The following is a description of a gene set: species: Mus musculus Genes down-regulated in prefrontal cortex (PFC) of mice carrying a hemizygotic microdeletion in the 22q11.2 region. Individuals with 22q11.2 microdeletions show behavioral and cognitive deficits and are at high risk of developing schizophrenia. We analyzed an engineered mouse strain carrying a chromosomal deficiency spanning a segment syntenic to the human 22q11.2 locus. We uncovered a previously unknown alteration in the biogenesis of microRNAs (miRNAs) and identified a subset of brain miRNAs affected by the microdeletion. We provide evidence that the abnormal miRNA biogenesis emerges because of haploinsufficiency of the Dgcr8 gene, which encodes an RNA-binding moiety of the 'microprocessor' complex and contributes to the behavioral and neuronal deficits associated with the 22q11.2 microdeletion. Human Gene Set: STARK_PREFRONTAL_CORTEX_22Q11_DELETION_DN from publication Stark KL, Xu B, Bagchi A, Lai WS, Liu H, Hsu R, Wan X, Pavlidis P, Mills AA, Karayiorgou M, Gogos JA (PMID 18469815), and this is the list of marker genes: NME1, LAMTOR1, CYC1, NIPA1, EIF3L, PSMC3, GPR83, COA3, TMEM147, EIF2B4, BOK, NACA, COMMD8, DCAF11, B4GALT3, DGCR8, GLS2, RPL36A, PSMB4, NARS1, KPNA1, SCNM1, KXD1, NME2, NDUFB10, STIP1, OCIAD2, INCENP, RHEB, PPP1R9A, HAGHL, TCEAL8, PHIP, EIF4E, PURA, DPM2, SGTB, MRPS28, CCT5, TIMM17A, PSMB6, DTNBP1, SMIM7, NDUFA2, UFC1, MED28, MRPS18A, TMA7 (translation machinery associated 7 homolog), PRDX3, NDUFA12, C1GALT1C1, MAPK10, GPATCH8, TSHZ3 (teashirt zinc finger homeobox 3), SRA1, C22orf39, NAA38, SLC25A20, NSG2, TSPAN31, C9orf85, SEC22B, TXNRD2, PDGFA, LYSMD4, ATP5F1C, RAD23A, HSD17B7, HS3ST4, ATP6V1E1, PRDX1, TST, INIP, MVD, GPI, ARPC5L, ZNHIT1 (zinc finger HIT-type containing 1), MRPL55, MLLT6, RARS1, MDH2 (malate dehydrogenase 2), CREB3, RPL8, EIF3K, MKKS, SUMO1, C19orf25, HIBADH, RGS20, EIF2S1, CUEDC2 (NCBI Gene Id 79004), RIT1, RPL15, NUDC, DDX56, ADCY8, C1QTNF4, MRPL17, ATP6AP1, SCG5, COX14, NUDT21, HAGH, USP34, SAC3D1, IDH3A, MICOS10, IDH1, TESK1, WDR17, BCKDHB, LGI2, NIPSNAP1, NDUFAF3, CISD1, SCN2B, SDHAF4, COPS6, SNX32, PPT1, ATOX1, SARS1, HSPBP1, ERI3, ATP5PF, SEC61B, HMOX2, MRPS17, NDUFA7, FIG4 (NCBI Gene Id 9896), TXN, DGCR6, PLCB4, COMT, NDUFS7, TRBC2, MRPL51, MRPL40, SNRPD2, H2AC25 (H2A clustered histone 25), TRA2B, RMND5B, TUBG1, CBX3, NSD2, CYCS, THOC7, KPNA2, HIBCH, EPM2AIP1, HSPA4L, EIF3F, OGFOD3, NR1H2 (NCBI Gene Id 7376), NDUFS3 (NCBI Gene Id 4722), GCSH, VDAC3, HIRA, PDCD6, IMPACT (NCBI Gene Id 55364), FNTA, LEPROTL1, MGST3, MPC2, PRELID1, PFDN6, POP7, MIS18A, ATP5IF1, RPL5, TLE4, CNDP2, AP2M1, CWF19L1, GDE1, KANTR, MPPED2, ARHGAP20, CNPY2, MICOS13, CYSTM1, ARK2C, PSMA3, SAMD5, SMARCB1, PRPS2, MTLN (NCBI Gene Id 205251), MBLAC2, HSPE1, PSMC1, MRPS23, COPS3, PCDH11X, DENND5B, SMYD2, TRMT10B, RAD23B, HPF1, ATP5PO, UQCRC2, TMEM165, PLEKHO1, PSMB3, FKBP3, STRBP (NCBI Gene Id 55342), ADH5, IFTAP, NDUFB11, UQCR11, TMSB10, SIRT2, DYNLRB1, TTLL7, GTF3A, NOP10, ARHGAP35, TANGO2, AHSA1, OAT, EIF1, TMEM208, DMAC1, RAB4B, TMEM44, SNHG10 (NCBI Gene Id 317786), UQCR10, CLNS1A, NUP88, USP1, PGRMC2, MRPL15, TPI1, OSBPL1A, SEC62, POLR1D, CARM1, ST13, FDPS, ESS2, NPRL2, DYNLL1, SAP18, ATP5MF, NDUFS1, RTN4R, ALCAM, CHN2, UQCC5 (NCBI Gene Id 440957), STMN3, TAF9, CRYZL1, IDH3G, LAMTOR2, MRPL11, FNDC4, DCTN6, HAPLN4, DAP3, TIMM23 (NCBI Gene Id 100287932), PHC2, U2AF1L4, MRPS12, ATP5PD, CARF, AKR1A1, ZDHHC16, UQCRFS1, MZT2B (mitotic spindle organizing protein 2B), TRIR (NCBI Gene Id 79002), ATP6V1D, ATP5ME, WDR45, ELOB, STMN2, UFSP2, PRODH, RPL18, PPP2R5C, SBDS, TMEM59L, ZNF511, UQCC2, PFDN2, MCTS1, IFNGR2, TXNL4B, SRP9, NDUFA9, SRR, ALDOA, CACYBP, SAR1B, CLDN5, RUNDC3A, C1QBP, RNF34, ROMO1, NDUFB4, METTL26, CYB561A3, CPSF3, NDUFA8, GUK1, NDUFS4, TXNDC17, WDR82, FAM162A, ARHGAP15, SLC25A46, ENOPH1, PRDX2, TCP1, FN3K, MRPL41, MRPL28, SNAPC2, UGP2 (UDP-glucose pyrophosphorylase 2), FMC1, GET3, DDRGK1, SELENOH, PIP4P1, SMU1, VPS13A, GNG13, SNRNP27, RTRAF, PRAF2, ATP5MG, SLC27A4, GP1BB, PSMA2, CCT2, SEMA3A, MRPS11, IPO9, BRWD1, NAXE, MLLT11, DNAJC15, BCAP31, RABL6, PSMG2, UBAC1, KDM1A, ELOF1 (elongation factor 1), BLVRA, SNX16, TMEM42, SEC63, USP39, METTL8, FAM136A, EIF3H, NDUFS8, TRAPPC2L, KRTCAP2, ELP5, PPP1CA, SCAND1, MEA1, BBLN, MYL4, LRPAP1, TOMM34, PDCD5, ABHD11, MRPL3, DGCR2, EIF6, PPM1L, TMEFF2, NDUFB2, RRP7A, NONO, DIPK1B, SS18L2 (NCBI Gene Id 51188), ACTR10, ACSL1, POLR1C, NDUFV2, TOMM20, VDAC2 (NCBI Gene Id 7417), BUD31, CORO7, TRIM59, TCEAL9, PDXDC1, OMG, CDK5, CHCHD1, H2AZ1, TMEM126A, EMP2, PSMD14, GINS4, FKBP2, IST1 (IST1 factor associated with ESCRT-III), SERF2, TM7SF2, PDHB, TMX2, NMT2, UFD1, ACOT13, GSKIP, GLG1, PFDN5, NDUFA11, NAGK, ZFTRAF1, LRRC4C, SLITRK4, POMP, ZDHHC8, MPI, CHMP4B, PSMA5, BCAP29, AKR1B1, SNORA74A, NFU1, TPD52 (NCBI Gene Id 7163), BNIP1, UBL4A, SLC25A5, TBC1D9B, MRPS22, GDAP1, COQ4, BSCL2, EIF4G2, BCCIP, JKAMP, PAK1, B4GAT1, TMEM256, MRPL57, HIGD2A (NCBI Gene Id 90241), NFIX, POLR2J, SLC25A39, SPSB3, CBR1, RPS17, COX7C, TIMM8B, EEIG1, ANK3, PSMC4, ABT1, OGFRL1, C4orf3, COPRS, PDE6D, FH, ALAD, S100A6, RAB26, ATP5F1E, RPL34, SNX7, SLC25A1, SMIM29, DENR, PPIL3, TRMT2A, FABP3 (fatty acid binding protein 3), NDUFS6, VPS35, RAB5IF, RPL4, TRMT112, PKIB, SNRPC, WTAP, NIFK, ARAP2, RESP18, RPL22L1, CCT3, ZNF121, MRPL42, NENF, PRXL2B, BAZ1B, YAF2 (NCBI Gene Id 10138), ELOC, DEK, MTHFD2L, SDHAF3 (NCBI Gene Id 57001), GABRD, STAU1, ASPH, CFDP1, TPD52L1, ELMO1, EMC2, TTC33 (tetratricopeptide repeat domain 33), SEC11C, ACAT2, PET100, IMMP1L, VPS4A (NCBI Gene Id 27183), COX5B, NTAN1, TLN1, SIK3, SMIM26, GOLGA2, C9orf72, RANBP1, TOMM40L, AIMP1 (NCBI Gene Id 9255), HCFC1R1, CZIB, COX7A2, CCDC127, CEP19, EVI2A, ARVCF, SLIRP, SSR4, RPL26, NUDT19, ZSWIM7